Given this list of marker genes JPT2, DNAAF5 (NCBI Gene Id 54919), PPARGC1B, CAPZA2, BMS1, CTNND2, ADGRF1, RHEX, CACNB4, WBP11, SCIN, PLXDC2, SHISAL1, TSPAN14, AKR1C2, SESTD1, TFAM, PRH2, CXXC4, SH3RF1, HTR1F, HTR7, NKD1, TGFB3, SLC44A1 (solute carrier family 44 member 1), GORASP1, TRIM10, RAD51B, MTERF3, HDAC8, S1PR3, RIMS1, ADSL, USP13, MYO3B (myosin IIIB), SLC8A1, AVEN, CNRIP1 (cannabinoid receptor interacting protein 1), IRAK4, HIF1A, PDCD4, DENND5B, KPLCE, CADM2, CXCL8, SLC4A8, ZBTB11, here is a description of the gene set: from publication Chen Y, Wang X (PMID 31504780) Genes predicted to be targets of miRBase v22 microRNA hsa-miR-4312 in miRDB v6.0 with MirTarget v4 prediction scores > 80 (high confidence targets). Human Gene Set: MIR4312 studied in species Homo sapiens